Given this list of marker genes Dedd2, Col6a1, Cdk5rap3, Apaf1, Dnase2b, Endog, Gper1, Kdm4a, Exog, Blcap, Acin1, Gata5, Il6, Ern2 (NCBI Gene Id 26918), Dicer1, Nmnat1, Foxl2, Vps54, Aifm1, Sharpin (SHANK-associated RH domain interacting protein, NCBI Gene Id 66081), Bok, Acvr1c, Dnase1l3, Cd24a, Cidea, Igfbp3, Dnase2a, Bax, Hsf1, Dffb (DNA fragmentation factor, beta subunit), Blvra, Cdkn2a, Hnf1a, Dffa, Top2a, here is a description of the gene set: studied in species Mus musculus The breakdown of structures such as organelles, proteins, or other macromolecular structures during apoptosis. Mouse Gene Set: GOBP_CELLULAR_COMPONENT_DISASSEMBLY_INVOLVED_IN_EXECUTION_PHASE_OF_APOPTOSIS